Given this list of marker genes MIRLET7B, AKT1, PINK1, MIR21, MET, MIR133A1, HGF, RACK1, TRAP1, PARK7 (NCBI Gene Id 113880), DDR2, MIR17, MIR92A1, here is a description of the gene set: studied in species Homo sapiens Human Gene Set: GOBP_NEGATIVE_REGULATION_OF_HYDROGEN_PEROXIDE_MEDIATED_PROGRAMMED_CELL_DEATH Any process that stops, prevents or reduces the frequency, rate or extent of hydrogen peroxide-mediated programmed cell death.